Given this list of marker genes MTMR2, GABRG2, GABRQ, MPDZ, GABBR2, LHFPL4, ARFGEF2, RTN1, ABHD17A, NSF, HNRNPD, NLGN3, RAB11FIP3, RPH3A, PRR7, GABRB2, DVL1, COL13A1, SYAP1, PRNP, KCNB1, FAM81A, ELMO1, KCTD16, HTR3E (NCBI Gene Id 285242), SENP7, DMTN, VAPB, RHOA, RPS3, GSK3B, PCDH8, AP2B1, ANK1, SLC1A7, DBNL, KCND3, STX4, ITGA8, TMEM108, BNIP3, CHRNA2 (cholinergic receptor nicotinic alpha 2 subunit), CABP1, NEFH, EPHB2, PICALM, CAP1, ADGRL2, C1QA, CACNG4, LRRC4B, TNIK, GABRE, ABHD17C, P2RX5, GABRA4, NTRK3, GRIP1, DLG1, DCC, GRM1, ANKS1B, DNAJC6, PTEN, VPS26B, PRKAR2B, KIF5A (NCBI Gene Id 84710), PDE4B, CADPS2, LPAR1, CHRNB1, DTNBP1, AKAP9, RPL8, GRIN2B, SLC4A10, PRKAR1B (protein kinase cAMP-dependent type I regulatory subunit beta), DLG3, GNA13, ATP7A (NCBI Gene Id 613259), ADRA2A, PTPRS, ADCY8, CALM3, SLC6A17, CDH1, GRM5, NRGN, NCDN, P2RX7 (purinergic receptor P2X 7), ADGRA1, ADGRB1, LRFN2, CASKIN1 (CASK interacting protein 1), FMR1, CHRND (cholinergic receptor nicotinic delta subunit, NCBI Gene Id 1144), SRCIN1, VASP, CHRM1, CTNNA2, PTK2B, HTR3B, RAB3A, S1PR2, RNF112, CBLB, CELF4, NCKIPSD, ARHGAP44, TACR1, EIF4A3 (eukaryotic translation initiation factor 4A3), RHOG, STXBP1, BRAF, HTR3A, APBA2, FRMPD4, GLRA2, SYN2, ARHGAP33, CHRM4, APBA1, BAIAP2, CHRNE, PALMD, RPL7, MEF2C, LIMK1, PPFIA1, FLNA, CSMD2, FLRT3 (NCBI Gene Id 23767), NR1D1, STAT3, SHISA6, UTRN, ITGB3, RAC1, WNT5A, SNX14, DTNB (dystrobrevin beta), CRIPT, TSC2, ADORA2A, ATP6AP2, ADD2, KCNMA1, APBA3, HTT, PLPPR4, CTNNB1, KIF3B, NETO2, FCGR2B, ENAH, GRIK4, EPS15, HCRT, FBXO45, P2RX2, RGS14, NLGN4X, TMUB1, ARF6, DRD1, SH3GL2, CLSTN1, LIN7C, IGSF21, GSG1L, CACNA1C, C1QB, CHRFAM7A, DMD, GABRB1, ITPR1, SWAP70, BRSK1, GABRA3, KIF5C, NLGN1, CNTN2, GABRD, PJA2, USP8, GRK3, ARRB2, KIF1B, PSD3, SNCA, SMCR8, LZTS3, ADCY1, LRFN1, ELFN2, GIPC1, PPFIA2, CAMK2N1, SYT1, RPS27, CPSF2, DAPK1, NPAS4, GRIK5, SCRIB, CSPG5, NCK2, PFN2, KCNC4, GABRA5, ARHGAP12, USP6, PCLO, ADORA1, PSD2, PCDHB13, KCND1, CLCN2, AMOT, RPS13, NSG1, DYNLL2, CD3E, MYL7, HIP1R, LIN7B, CDH10, ARHGEF9, RTN3, SIPA1L1, RTN4 (reticulon 4), TFRC, GSK3A, DOCK1, RPL6, ATXN1, BEGAIN, GRIA1, CDK5R1, ATG5, PPP1CC, SEMA4C, KCNC3, PARN, DRD2 (NCBI Gene Id 91906), GRIN2C, ARHGEF15, CALB1, FRRS1L, UBE3B, SLC12A5 (NCBI Gene Id 57468), PPP1R9A, MAP1B, EPS8, DLG5, TMEM240, SENP1, FGF7, ARC, THY1, GRIA4, SIGMAR1, RPS25, BCR, TSC1, RGS7BP, F2R, DOCK10, LRRTM1, P2RX6, KCNN2, NOS1, APP, DAG1, GNAQ, SLC17A7, FXYD6, VPS35, CPT1C (NCBI Gene Id 65943), GABRG3, GRIN1, ZNF804A, INPP4A, SYNDIG1, RYK, KCNA2, EEA1, ADAM10, CHRNA4, EFNB2, CPEB3, PDLIM5, EIF3A, PRAF2, RPL14, ATP2B2, SAMD14, TANC2 (NCBI Gene Id 80259), HOMER2, CARMIL3, RNF220, STX1A, ITPKA, MAPT, KCNA4 (NCBI Gene Id 3740), IQSEC1, SORCS3, GRIN2D, NEURL1, CLSTN3, CHMP2B, CHRNA5, NEDD4, IQSEC3, CTTN, CAMK2A, GLRA3 (glycine receptor alpha 3), PLEKHA5, SLC6A6, GABRA6, SRGAP3, LRRTM3, LYN, CBLN1 (NCBI Gene Id 869), PALM, GABBR1, CLSTN2, PDXP, SEMA4D, PIAS1, NRP2, P2RX4, SHROOM4, CAMK1, LRRC4, GPR179, ERBIN, SYT11, GLRB, SOS1, GPSM2, PCDH10, RMDN3 (NCBI Gene Id 55177), SHANK2, NEGR1, DISC1, CHRNA6, SLITRK5, CHRNG (NCBI Gene Id 1146), DLG2, C1QC, SLITRK2, FGFR1, SLITRK3, PCDH17, DBN1, MET, CYP46A1, GRID1, LRRTM4, JAK2, GPR158, KCNJ4, KIF17, CHRM5, KCNC2, SUSD4, FXR1, AP3M1, FAIM2, UBE2M, HIP1, SRGAP2, PTCH1, AGO2, MAPK8IP2, DSTN, PLCB1, NEFM, SH3KBP1, DNM3, SLC29A1, LATS1, HPCA, ZDHHC12, GRM7, EPB41L3, SHANK1 (NCBI Gene Id 50944), FYN, DGKI, MOB4, NCKAP1, ITGA5, ARF1, SLC6A9, CNKSR2, NECAB2, UBE2I, KIF2C, NPFF, INA, WASF3, TPPP, GABRB3, DGKB, DLGAP4, GNB5 (NCBI Gene Id 82962), EPHA7, KCTD12, GNAO1, SUMO1, LRRK2, PUM2, DAGLA, GIT1, NEO1, GABRR2, SYNPO, NTRK2, LRFN4 (NCBI Gene Id 78999), PAK3, KIFAP3, NETO1, ARHGEF7, SHISA9, HOMER1, LZTS1, STRN3, BCL11A, P2RX3, PURA, PIK3C3, LAMA2, AURKA, DRP2, GABRR1 (NCBI Gene Id 2569), PRKN, SLITRK1, HTR2A, NAPEPLD, PRR12, SENP5, DLGAP2, RPL18A, SLC6A11, ABL1, DLGAP3, AKAP5, ZMYND8, ADD3, INSYN1, P2RX1 (purinergic receptor P2X 1), CHRM3, RAC3, FGF22, LRRTM2, GRIA2, RGS9, CRTAC1, CHRNB2, KALRN, ELFN1, PTPRO, MT3, CHRNA7, PDLIM4, KPTN, SLC8A1, SIPA1L3, DLG4, ALS2, ASIC1, STAU2, PSD, ABI3, SEPTIN11, LRFN3, GRID2, CNTN1 (NCBI Gene Id 1272), ZDHHC15, CASP3, DIP2A, SORCS2, STX12, GLRA1, NGFR, AP2M1, GPHN, DOK7, CTNND2, AP2S1, CAP2, VANGL2, RAPSN, ITGA3 (NCBI Gene Id 4454), PDPK1, PAK6, SPTBN2, LNX1, RPLP0, NLGN4Y, PPP1CA, CUL3, SPOCK1, GRID2IP, HCN1, CYFIP1, METTL5, AKT1, MECP2, PRRT1, ATP1A1, MPP2, MKLN1, CRHR1, SPTB, FARP1, ANK3, ZDHHC8, RNF10, CAMK2B, FBXO2, MYH10, SLC6A3, CHRNA9 (cholinergic receptor nicotinic alpha 9 subunit), PRRT2, CHRM2, SNX27, SLC24A2, MRTFB, MARK1, UBE3A, GRIK3, CACNG5, GNG3, GABRA2, MAGEE1, RAB17, PRKACA, HTR3C, TRPV1, DGCR8 (DGCR8 microprocessor complex subunit), PRICKLE1, GABRG1, STRN, RAB11A, BAALC, RPL30, GHSR, FAAH, EGLN1, MYO9B, ABLIM1, PSEN1, NEDD8, TRIO (NCBI Gene Id 7204, trio Rho guanine nucleotide exchange factor), RPL38, CDC42, GRIN2A, MDM2, DROSHA, FRMPD2, FUS, AGER, RUSC1, ZDHHC5, CALR, EEF2, OPRK1, KCTD8, DNM2, FCHO1, CFL1, SLC1A1 (NCBI Gene Id 6505), ADAM22, GRIA3, IGSF9, CRYAB, MINK1, PLCB3, EIF4EBP2, KCND2, TENM2, SYT17, SYNE1, LRFN5, STX3, CNIH3, ADGRB3, DGKQ, ARHGAP32 (NCBI Gene Id 9743), ICAM5, PKP4, LASP1, CNIH2, EEF2K, RPS19, SLC8A3, GRIK2, CACNG8, INSYN2A, SHISA8, SUMO2, RPS18, SLC30A1, AP2A2, ACTN2, NLGN2 (NCBI Gene Id 57555), RGS7, RTN2, CLTA, SHISA7, GABRA1, SH3GL3, GRIN3A, HAP1, STRN4, SYN3, GPM6A, CPLX1, USP50, NEFL, GRIK1, ACP4, WASF1, IGSF9B, SYNGAP1, SNX6, GRM3, GRIN3B, KCNJ2, CRKL, ANP32E, SPTBN1, CAMK2G, ASIC2, SYN1, SHC4, KCNC1, CPLX2, ABI2, MAP2K1, AP3D1, PIN1, DRD4, KLHL17, SEMA4B, NCS1, PTPN1, FLRT2, SLC9A5, CRMP1, DDN, NAPA, GRM2, DLGAP1, KPNA1, CLMP, PPP3R1, MAGI2, GOPC, OPRD1, NPTN, PICK1, ZC4H2 (zinc finger C4H2-type containing), GRK2, CHRNA10, CAMK2D, LRRC7, IL1RAPL1, CACNG7, C9orf72 (NCBI Gene Id 73205), SHANK3, PCBP1, ZDHHC17, CHRNB3, SLC16A7, RAB3GAP1, SLC8A2, FXR2, ABI1, SH2D5, CHRNA1, CPEB4, HOMER3 (NCBI Gene Id 9454), SSPN, NRP1, ABHD6, CACNG3, IGF2BP1, ERBB4, NECTIN3, NOTCH1, PPP1R9B, VPS52, PIAS3, ARF4, RPS14, KCNK2, ANK2, MIB1, PAK2, SEZ6, TAMALIN, AGAP1, ABR, AP2A1, CTTNBP2, CDK5, DNAJB1, CHRNA3, PTCHD1, DNAJA3, P2RY1, HTR5A, CAPZB, ABHD17B, PLXNB1, RASGRF2, RHEB, BSN, GRIPAP1, CNR2, MUSK, GHRL (NCBI Gene Id 51738), DIXDC1, VWC2, NSG2, AGAP3, ITSN1, LRP4, SLC6A4, GABRR3, CALY, NTSR1, SEMA4F, ADD1, ARPC2 (actin related protein 2/3 complex subunit 2), PPP3CA, TANC1, CAPN2, GPR50, RPL10A, TRIM47, LRP8, EIF3E, ZDHHC2, EIF4E, GPER1, IGF1, OPHN1, ACTB, RPL12, ELAVL1 (ELAV like RNA binding protein 1), LIN7A, GAP43, ATP1A2, ATAD1, CPEB1, ITGB1, BMPR2, CACNG2, KIF5B, DOCK4, LRRC4C, TRAPPC4, CHRNB4, KCNH1, NRCAM, HTR4, ACTN4, FABP5, HTR3D, NSMF (NMDA receptor synaptonuclear signaling and neuronal migration factor), PRKCG, EPHA4, here is a description of the gene set: The part of a synapse that is part of the post-synaptic cell. species: Homo sapiens Human Gene Set: GOCC_POSTSYNAPSE